Given this list of marker genes CTH, KIT, SOD2, MIR18A, MIR21, MIR145, MIR1-1, MIR140, EFEMP2, MIR424, ENG, MIR125B1, GPER1, here is a description of the gene set: species: Homo sapiens Any process that activates or increases the frequency, rate or extent of vascular smooth muscle cell differentiation. Human Gene Set: GOBP_POSITIVE_REGULATION_OF_VASCULAR_ASSOCIATED_SMOOTH_MUSCLE_CELL_DIFFERENTIATION